The following is a description of a gene set: Human Gene Set: HOXB6_TARGET_GENES species: Homo sapiens Genes containing one or more binding sites for (HOXB6) in their promoter regions (TSS -1000,+100 bp) as identified by GTRD version 20.06 ChIP-seq harmonization. from publication Yevshin I, Sharipov R, Kolmykov S, Kondrakhin Y, Kolpakov F (PMID 30445619), and this is the list of marker genes: NME1, TSN, LYAR, CHMP2A, HOXB7, BAIAP2, IRAG1-AS1, HTD2, PDLIM5, PMF1-BGLAP, ZRANB3, ALG5 (NCBI Gene Id 29880), ODAD3, G3BP2, VPS13A, UBAC2-AS1, PAPOLA, ACADVL, TUBG1, TP53I3, GADD45G, PINX1-DT, TECR, FAM13B-AS1, DELE1, COQ10B, CALCOCO2, DYNC2I1, TP53BP1, SRRM5, MVB12A, ULK4, ABHD2, MRPL1 (mitochondrial ribosomal protein L1), IFT70A, TMEM222, INO80C, SLC50A1, MKNK1, MYCBP, EDEM3, ATP8B1, AANAT, SERF2, BAG6, MRPL44 (mitochondrial ribosomal protein L44), ANKRD26, HMGCR, PISD, RPL37, TULP3, LSM4, OSGEPL1, ZBTB45, DLG4 (NCBI Gene Id 1742), DYNLT4, CTDSPL2, ZNF593, TMCC3, TMEM198B, OSGEPL1-AS1, GOPC, CDK18, FZR1, HBP1, CORO7, COQ6, RBBP8, EXOSC1, CZIB-DT, NIPA2, MYSM1, FBXW7, LIAT1, TPRG1L, RHOC, TMEM62, IARS1, WASHC4, MAP2K1, SH2D3C, MKRN1, HACD3, SRSF1, HNRNPH1, LINC02166, TAF13, UIMC1, USP14, ZNF514, CNTFR-AS1, BSCL2, S100A11 (NCBI Gene Id 6282), ZDHHC16, GATC, BTBD19, TIPARP-AS1, PPRC1, CDK10 (cyclin dependent kinase 10), NCR3LG1, ABCF2, THAP8, SPAG16-DT, ZC3H3, BCKDHA, SEMA4B, DENND4A, GPI, PRR13, INTS13, WDR62, ARMC2, DOCK4, FDPS, PNPLA6, ZFP36L2, TRIAP1, EHD1, MT1X, HSP90AA1, CEP152, HIP1R, ATP5MJ (ATP synthase membrane subunit j), UBXN7, HSPA14, MRNIP-DT, CCDC34, IWS1, TBC1D8, KICS2, STAT2, DNAJC14, ZBTB49, ADAM10, CLN8, TRMT10A, WDR35, N6AMT1, HAUS5-DT, ARPC5L, PRMT5-DT, IFT172, GVQW3, RSPH1-DT, EME1, CRIPT, DNAJB1, ERCC1, CROCCP2, TRAPPC13, DHRS7B, APTR, CRBN, MIR200C, FOXA3, ZSCAN21, SLC25A51, IQCC, NDC1, NLE1, RAB3GAP2, TPT1, FITM2, ANKHD1, METTL4, TOMM34, EFHC1 (EF-hand domain containing 1), TMEM65, FBXO15, EFNA4 (NCBI Gene Id 1945), HOXA-AS3, KAZALD1, ZBED5, MSL2, B9D1, RARS1, DDIAS, SMG9, RHOA, PIGF, OCIAD1, PINX1, USP8, DIAPH1 (diaphanous related formin 1), TMEM218, PSAP (prosaposin), CDNF (cerebral dopamine neurotrophic factor), C1D, EWSAT1, TMEM143, USO1, PREPL, SLC12A9, EIF3K, GAU1, CLN8-AS1, THAP12, PI4K2A, S100A6, RSPH1, NME1-NME2 (NCBI Gene Id 654364), B3GAT3, CHURC1, APEH, CHD4, DDX21, EIF3M, TIPARP, GFOD2, ATP6V0D1-DT, HEXIM1, PAPOLA-DT, PKN2, TMEM250, EID2B (NCBI Gene Id 126272), PPM1F, GSDMD, PACC1, MCCC1, NCBP2, CFL1P1, SEH1L, TLDC2, HRAS, RNPC3-DT, LARP4, HPSE, ZNF277, SDCBP, TRMT61B, LARS1, MBD4, TIMM21, HASPIN, TFG, PPFIA3, HILPDA-AS1, SAE1, CASC11, TFB1M, CZIB, GAB1 (NCBI Gene Id 2549), TMC3-AS1, HCG14, P4HA1, U2AF2, LINC02482, ATP10B, ARF3, RNF32-DT, NMRAL1, ELOVL1, LINC01703, LRRC23, ALAS1, C16orf46-DT, TIMM8A, RAB11A (NCBI Gene Id 8766), THOC6, CSNK1G1, LRRC56, MIGA1, GIPC2, CORO7-PAM16, SETDB1, MYOM2, ZHX1-C8orf76, MIR4453HG, HMOX2, TMEM87A, CHERP, EXOSC5, PARP2, MYL5, ANKHD1-EIF4EBP3, MRNIP (NCBI Gene Id 51149), PIK3C2B, RPP14, DNAJB4, LIAS, HNRNPA0, DESI1, IPO11, DPP8, NBN, GUK1, C14orf119, RBM18, TIGD4, RNF139, RRM2B, ZBTB17, STX6, DNAJA3, RNASEH1-DT, TOP2A, FDXACB1, IMPDH2, XRCC6, SLC4A2, ETNK1-DT, FAM222A-AS1, AP1S1, NAXE, CNOT11, OSER1, GCC2 (NCBI Gene Id 9648), EPS15L1, SYNGR4, CFAP68, MIR200CHG, TBC1D19, C1orf43, ABCA7, FAM185A, FXYD5, TMEM134, PCM1, RPL21, RIC8B, TIMELESS, LINC02851, WDR35-DT (WDR35 divergent transcript), SNORD59A, ETNK1, LINC03014, ENSG00000275765, CLCN6, CDK13, RETSAT, RNPC3, CHCHD3, SLC33A1 (solute carrier family 33 member 1), UQCC5, GPRC5D-AS1, CACUL1, CDK5, ENSG00000273162, POLG2, WDCP, ATAD1, ZNF337-AS1, RNVU1-2, TSEN2, GPR39, NABP2, XRCC5, FAM220A, TCAIM, ARF4, FICD, TMEM144, RPL9, ELP3, MCOLN1, CFAP43, SETD4, DCP1B, IRAK1BP1, CTDNEP1, C1orf74, G3BP1, RPPH1, PLD3, MIR3912, USP40, WDR55, ABT1, CENPW, POU2F1-DT, TTC5, MTHFR, TPGS2, ZNF576, LINC01978, UBAP2L, MRFAP1L2, B3GNTL1, HSD17B1-AS1, DEPDC1-AS1, AKAP9, ACP1, NPM1, DNAJC3-DT, KIAA0825, PCCB, ELP5, ADPGK, PCLO, SPRTN, CHD2, CEP70, TOLLIP, MRPS27, RDM1 (RAD52 motif containing 1), C19orf47, DCAF7, PPP2R3B, SYMPK, C18orf54, INO80, RABGEF1, UFSP2, PDRG1, TRMO, STARD5, CBX8, MAPK10, TMEM69, ZNF250, ANO7L1, SF3B1, RNA5SP21, EPRS1, MBLAC2, PGM1, AP1AR-DT, H2BC26, MAZ, NANP, PSMD3, CEP41, EIF3E, MAP4K1, HSD17B12, SCYL2, MARCHF3, TMEM19, UQCRC1, DNAJC3, KALRN, NFX1, POLN, ZBED5-AS1, PRCP (prolylcarboxypeptidase), FTO, PIERCE2, UBAC2, MRPL55, SKA1, EXOC8, ODAD1, POLR3G, DYNLT1, TRIM23, C2orf15, RNASEH1, RSPH3, TSGA10, SETD9, KCNK7, SHLD3, SRRT, HNMT, ABITRAM, PRMT5, FUBP1, SMG7, HEXIM2, HNRNPK, SLTM, NDUFB3, CDIN1, HEXIM2-AS1, PBRM1, C12orf75, ZNF862, ACAP2, WEE1, MRPL27, SH3YL1 (SH3 and SYLF domain containing 1), GAPDH-DT, LGMN, RPGRIP1L, RAB5IF (RAB5 interacting factor), FOXN2, NUCB1, CSNK2A1, RNU6-92P, HCFC1R1, EPS8, SAP18, RPF2, IRGQ (immunity related GTPase Q), GSTO1, RSPH14, RETREG3, NDC80, CTDSPL2-DT (NCBI Gene Id 120017340), NME9, SYTL2, RNF139-DT, SPAG7, MAN1B1-DT, DNAJB12, MST1P2, PPP2CA-DT, RRAGC-DT, HSD17B4, BST2, RSBN1L, BDP1 (B double prime 1, subunit of RNA polymerase III transcription initiation factor IIIB), BISPR, PPM1F-AS1, EFEMP2, VTA1, DNMBP, SMG7-AS1, GMNN, WDR20, PDCD6IP, DNAL1, TCTA, LINC02086, LZTFL1, GRPEL1, FNIP1, POU2F1, UBE2O, HILPDA, HAUS5, ARFIP1, SNED1, ENSG00000241525, ASB8, KIFAP3, RNF141, PPA1, PPP5C, ESYT1, RNF41, KNL1, MAPRE3, SNHG6, RFX1 (regulatory factor X1), AATF, MTTP, TASOR2, NCBP2AS2, STARD6, PTPN13, TAGAP-AS1, EFR3B, MACROD2, SLC35E3, MAP3K14, GPBP1L1, EXOSC8, PRC1, EFNA4-EFNA3, OSER1-DT, COPS7A, ZNF195, RSU1, SSBP2, SH2D3A, SELENOK, RN7SKP175, GAPDH, LINS1, C1orf226, ERBB3, XRCC2, NF2, IFT122, ZNF584, CCDC30, SUPT7L, NBPF1, PRKCSH, SYN2, STX12, ATP5ME, GSS, MRPS17, HAUS3, KIAA1328, MRRF, ELMOD3, OAZ2, FUS, TMED1, ZMAT5, TPT1-AS1, RNGTT, CFAP96, ARMC10, ZC3H10 (NCBI Gene Id 84872), AP1AR, TIPIN, PTEN, HMGN1, TNKS, ATP5F1B, ATP6V0D1, PHPT1, C16orf46, FADS1, MDM2, CNDP2, SPAG16, ATP6V1C1, CARS2, CCPG1, MAGOHB, DVL2 (dishevelled segment polarity protein 2), KIAA1191, ELP1, GANC, ASCC3, LDAH, STARD3, GOLGA5, TMEM179B, MAN1B1, SEL1L2, DEPDC4, COX7C, MIR4757, TRIM37, RAB10, PPP2R1A, CDK4, PMF1, XPR1, WDR6, CHURC1-FNTB, MET, FBXL13, RAD52, RFX2, WDR73, SCAF11, ZHX1, PCSK5, YWHAZ, PPP2CA, HMGB3P22, ATF6B, ZNF33B, SLC4A1AP, RNF32, DNAJC8, PCGF1, UBR5-DT, TTLL4